The following is a description of a gene set: from publication Chen Y, Wang X (PMID 31504780) Genes predicted to be targets of miRBase v22 microRNA hsa-miR-10393-3p in miRDB v6.0 with MirTarget v4 prediction scores > 80 (high confidence targets). Human Gene Set: MIR10393_3P species: Homo sapiens, and this is the list of marker genes: RHOF, CNOT2, ENPEP, SOX8 (NCBI Gene Id 30812), GTPBP10 (NCBI Gene Id 85865), AGAP5, PLEKHG1, CSGALNACT2, ARL3, TUBE1, PCDHA3, BTBD10, CHD1, NDRG2 (NCBI Gene Id 57447), YWHAE, KDM5C, CDK8, TFB1M, AKR1B1, COMT, EEPD1, NR3C1, NFKB1, F8, PCDHA1, PKDREJ, INVS, PCDHAC1, CCDC39, VGLL2, PCDHA7, PCDHA4, ZNF280A (NCBI Gene Id 23747), THSD7B (thrombospondin type 1 domain containing 7B), FGFR1, RPA1 (replication protein A1), PCDHA8, KIRREL1, SFSWAP, NOP9, CRIM1, TRAK2, SLC7A6 (NCBI Gene Id 9057), ERRFI1, RTL5, SMOC2, TERF2IP, PCDHA12, PCDHA6 (NCBI Gene Id 56142), AGAP9, FKTN, PCDHA10, AGAP4, GPR3, TRPC5OS, LRP4, COBL, LDLRAP1, ANKRD27, YIPF4, SENP1, ARHGEF17, LAMA3, AZI2, TECRL, RANBP6, VGLL4, NLGN4Y, GPCPD1, CTNND2, ADAM21, DOCK3, GPX8, IP6K3, PCDHA11, AGAP6, ZNF485, ZBTB14, IFIT2, NIF3L1, DCTN2, VPS54, GASK1B, RNF170, BCL11B, FSCN1, LTA, AGAP11, PTEN, CPPED1, RAB5C, AP4B1, SLC25A5, MAP3K2, PCDHAC2, PCDHA13, PCDHA5, MAN1A2, AP3D1, NGFR, LRRC38, PCYT1B, POLH, TAX1BP1, MAB21L1, ATP6V1A, PCDHA2, TNFSF10, STON1